The following is a description of a gene set: Genes down-regulated in comparison of naive vs effector CD8 T cells (4-5 days postinfection). Human Gene Set: GSE10239_NAIVE_VS_DAY4.5_EFF_CD8_TCELL_DN from publication Sarkar S, Kalia V, Haining WN, Konieczny BT, Subramaniam S, Ahmed R (PMID 18316415) Using killer cell lectin-like receptor G1 as a marker to distinguish terminal effector cells from memory precursors, we found that despite their diverse cell fates both subsets possessed remarkably similar gene expression profiles and functioned as equally potent killer cells. However, only the memory precursors were capable of making IL-2 thus defining a novel effector cell that was cytotoxic, expressed granzyme B, and produced inflammatory cytokines in addition to IL-2. This effector population then differentiated into long-lived protective memory T cells capable of self-renewal and rapid re-call responses. Mechanistic studies showed that cells that continued to receive antigenic stimulation during the later stages of infection were more likely to become terminal effectors. Importantly, curtailing antigenic stimulation towards the tail-end of the acute infection enhanced the generation of memory cells. These studies support the decreasing potential model of memory differentiation and show that the duration of antigenic stimulation is a critical regulator of memory formation species: Homo sapiens, and this is the list of marker genes: UBA2, MAD2L1, TK1, PTMS, MARCHF10, FIGNL1, ALG6, TIPIN, GINS1, CKAP2, COL5A2, SDCBP2, EXO1, NUDT5, TYMS, RAD51, SRSF2, UHRF1, SEC13, ORC6, TMEM163, SNRPA1, MCM4, TNFRSF1B, TSPAN33, PGK1, GMDS, TIAM1, LRR1, SKIC8, SYCE2, ATP2A2, PCLAF, RFC4, PRMT1, ZNF367, LITAF, CHEK1, DYNC1LI2, APOO, E2F3, GEMIN2, RAB34, E2F8, DUT, GIMAP7, LGALS1, SIAH2, DHFR, PARPBP, TRIP13, NEIL3 (NCBI Gene Id 55247), IRF8, MEMO1, CDCA8, MLEC, TSPOAP1, FABP5, MINDY3, RCC1, GNPDA1, ERH, PRC1, FRMD4B, MDFIC, LMNB1, MAPK6, BUB1B, MBNL3, RFC3, RAD23B, RRBP1, HNRNPLL, ALG10, DIP2A, SLC25A13, CASP7 (caspase 7), PTGER2, PBK, PGRMC1, DDX39A, ALDH7A1, CLDN12, NUDT1, PRDM1, SQLE, GABPB1, ZNF503, MRPL18, ZFAND4, KNTC1, KPNA2, CRELD2, NEDD1, RFC5, SERPINB9, IL1R2, ORC1, DYNLL2, CASP3, PRIM1, MTFR2, PPIL1, PDSS1, WDHD1, TUBB4B, RILPL2, INCENP, COQ7, CDKN1A, CDC7, SEPHS1, STMN1, SLC15A3, DSTN, PLK1, BARD1, SSR1, DECR1, CCNA2, FAF1, LRP8 (LDL receptor related protein 8), PSAT1 (NCBI Gene Id 29968), TMCO1, AURKB, GEM, MCM5, ACOT7, CYFIP1, IFNG (NCBI Gene Id 3458), DOC2A, RAD54L, AP3S1, CDCA5, LACTB2, NUP37, MRPS18C, ANXA2, SMC2, CDC20, FAM185A, KLRC1, OXSR1, COPS5, DTL, MAGOHB, CKS1B, PLIN2, ZWILCH, DNASE1L3 (NCBI Gene Id 1776), USP14, RANBP1, PMVK, PHLDA1, DESI2, NRAS, SAP30, NDC1, PLSCR1, SELENOI, MANF, SAV1, MT1E, MELK, GINS2, CCNE1, KIF22, STT3A, CCNB2, GFOD1, HLA-A, PRELID3B, NPM3 (nucleophosmin/nucleoplasmin 3), ARHGAP11A, RRM1, DUSP4 (NCBI Gene Id 1846), FARP1, TEX30, ASRGL1, HMGB2, YBX3, OPA3, CASP1, ARL6, EHD4, PSMA5, HK2, FEN1, CCDC34, RFWD3, STX11, RAN, UCHL3, NAA20, CXCL14, ABCB10, IRF4, ATP5IF1, ACSM1, TRIM37